Given this list of marker genes LRRC4C, API5, ENSG00000306978, LINC02745, LINC02741, LINC02740, RAG1, LINC01499, LINC02760, LINC01493, IFTAP, HNRNPKP3, LINC02759, RAG2, ENSG00000307763, TTC17, DNAAF11P1, TRAF6, RPL7AP56, RNU6-365P, RNU6-99P, here is a description of the gene set: studied in species Homo sapiens Human Gene Set: chr11p12